Given this list of marker genes Gdf5, Pth, Sox5, Maf, Efemp1, Ihh, Axin2, Mkx, Ccn2, Wnt9a, Six2, Bmp4, Glg1, Por, Mdk, Adamts7, Thrb, Snai2, Ltbp3, Prkg2, Smad7, Hoxd11, Ccn4, Sox9, Lnpk, Chadl, Loxl2, Gdf6, Smad3, Rflnb (refilin B), Rflna, Zfp219, Scin, Gli2, Nkx3-2, Trps1, Mboat2, Hoxa11, Bmp6, Ctnnb1, Rarg, Tgfbr1, Shox2, Pkdcc, Pthlh, Gli3, Adamts12, Fgf18, Rela, Zbtb16, Mustn1, Nr5a2, Rarb, Runx2, Bmpr1b, Grem1, Ptpn11, Sox6, here is a description of the gene set: Any process that modulates the frequency, rate or extent of chondrocyte differentiation. species: Mus musculus Mouse Gene Set: GOBP_REGULATION_OF_CHONDROCYTE_DIFFERENTIATION